Given this list of marker genes Mbtd1, Trpc7, Pfkm, Myo1c, Rhoq, Ctnna1 (NCBI Gene Id 66546), Igf2bp3, Tsc22d2, Trim14, Dtna, Plag1, Ccne2, Ift70b, Pkn2, Samd8, Cngb3, Gpr137c, Ulk2, Cnep1r1, Ice2, Serpinb2, Rfx7, Tpd52l2, Vegfc, Zfp513, Sort1, Rap1a, Rab18, Nfat5, Rab14, Bahcc1, Mindy2, Vps26a (NCBI Gene Id 30930), Pramel3c, Olfm3, Etv6, Snx30, Rnf111, Gpc5, Mmrn1, Acvr2a, Sos1, Setbp1, Elf2, Zfp275, Sgk3, Sla, Pramel3b, Zfp516, Sppl3, Smad4, Ddhd1, Dst, Brinp1, Kpna4, Zfp85, Zfp81, Lpar1, Lamtor3, Osbpl3, Antxr2, Map4k3 (NCBI Gene Id 78862), Dipk2a, Cert1, Zfp91, Cxadr, Togaram1, Elfn1, Fndc3a, Arfgef1, Hnrnpr, Zfp367, Heatr5a, Fosl1, Snx24, Bmpr2, Sowahb, Zfp810, Nbeal1, Ric3, Anln, Dclre1c, Rps6kb1, Cp, Cdh2, Cdkn1b, Nexmif, Ccl11, Necab3, Tgif2, Trim44, Osbpl8, Nr3c1, Pik3r6, Adal, Pik3r3, Mtfr1 (NCBI Gene Id 76994), Jade3, Nsd3, Pcnx1, Ctnnd1, Rnf144a, Rph3al, Rab12, Ppp4r1, Slk, Pdc, Sox30, Kctd12, Ifngr2, Dvl1, Etv1, Zzz3, Hsbp1, Zfyve16, Rora, Tom1l2, Sh2b3, Hnrnpk, Wnt9a, Snx12, Gramd1c, Kras, Pik3ca, Lrrc18, Col28a1, Mideas, Dppa4, Tm9sf2, Klhl2, Ccnd1, Elovl2, Peak1, Itsn2, Pcm1, Ubp1, Dhdds, Gbx2, Limch1, Fam91a1, Fbxl3, Med13l, Rlim, Pcdh17, Txnrd3, Tnfrsf1a, Ddx3y, Tiparp, Atxn1, Ash1l, Ino80d, Pcgf6, Galnt6, Nufip2, Cdk1, Atf7, Rapgefl1, Rreb1, Clcn3, Gprin3, Zfp800, Nfkbie, 2210408I21Rik, Chic1, Cdc42ep4, Frem1 (NCBI Gene Id 329873), Taok1, Dock7, Ubl3, here is a description of the gene set: Genes predicted to be targets of miRBase v22 microRNA mmu_miR_122b_5p in miRDB v6.0 with MirTarget v4 prediction scores > 80 (high confidence targets). Mouse Gene Set: MIR_122B_5P from publication Chen Y, Wang X (PMID 31504780) species: Mus musculus